Given this list of marker genes AMPH, DOC2A, SLC30A3, SYT1, HCRT, PALM, CHGA (chromogranin A), RAB3A, SYT5, VAMP2, APBA1, SYN2 (NCBI Gene Id 6854), here is a description of the gene set: Human Gene Set: MODULE_381 Genes in the cancer module 381. species: Homo sapiens